The following is a description of a gene set: species: Mus musculus Mouse Gene Set: GOBP_HEMOSTASIS The stopping of bleeding (loss of body fluid) or the arrest of the circulation to an organ or part., and this is the list of marker genes: Anxa8, Hrg, Cd36, Mmrn1, Mfsd2b, Gla (galactosidase, alpha), Pdpn, Tspan18, F11r, Ptprj, Adamts13, Tlr4, Kng1, Pros1, Fzd6, Fbln1 (fibulin 1), Ephb2, Gas6 (NCBI Gene Id 14456), Cd40lg, Fga, Pdia2, Ubash3a, F2rl3, F13b, F2rl2, Vkorc1, C1galt1c1, Tspan8, Tspan32, Stxbp3, Tspan9, Wnt3a (wingless-type MMTV integration site family, member 3A), Pdgfra, Pdgfb, Tfpi, Angpt4, Prrg2, Slc4a1, Slc6a4, Prkca, Slc7a11, Rasa3, Pf4, Gp9, Lilrb4a, Tpsab1, Adtrp, F10, Proz, P2ry1, P2rx1, Fgb, Ap3b1, Cpb2, Tec, Thbd, C1qtnf1, Angpt1, Procr, Serpine2, Nbeal2, Il6ra, Prdx2, Kng2, Thbs1, Klkb1, Foxa2, Pla2g4a, Hps1, Sh2b3, Prkg1, Gp6, Gp1ba, Gp5, Serpinc1, Anxa5, Lyn, Serpinf2, Prkcd, F3, Zfp385a, Rap2b, Hpse, Serpina10, Vtn, Hps4, Itgb3, Tubb1, Fgl2, Ubash3b, F9, Gnas, Bloc1s3, Cfh, Prss56, Ctsg, Vwf, Pik3cb, Tfpi2, Adra2c, Fcer1g, Shh, Pdia3, Cav1, St3gal4, Itpr3, Emilin1, Bloc1s6, F2r, Axl (AXL receptor tyrosine kinase), Mpig6b, Angptl6, Bloc1s4, Cd9, Apoh, F11, Fermt3, Enpp4, Prrg3, Ppia, Gp1bb, Angpt2, Plg, Adamts18, Psg23, Angptl7, Pip5k1c, Prkcq, Hps5, Hgfac, Dtnbp1, Tph1, Apoe, F13a1, Fgg (fibrinogen gamma chain, NCBI Gene Id 99571), Gata1, Nfe2l2, Pdia6, Papss2, Gna13, Treml1, Comp, F12, Tbxa2r, Fundc2, Hnf4a, Lnpk, Lyst, Proc, Tmx1, Srf, Ano6, Evl, Plek, S100a9, Entpd1, Plau, Anxa2, Serpine1, Hps6, Angptl1, Emilin2, Angptl2, P2ry12, Tyro3, F8, Plat, Svep1, Fgl1, Vps33b, Prrg1, Pdia4, Angptl4, Gnaq (NCBI Gene Id 71788), F5, Syk, F2, Pear1, Rab27a, Ptpn6, Alox12, Cela2a, Selp, Plaur, Stxbp1, Serpind1, Ceacam1, Adra2a, Mertk, Serping1, Htr2a (5-hydroxytryptamine (serotonin) receptor 2A), Entpd2, Prrg4, Jak2, Tmprss6, Il6, Pdgfa, Flna, F2rl1, Adra2b, F7, Anxa7